The following is a description of a gene set: from publication Collison LW, Chaturvedi V, Henderson AL, Giacomin PR, Guy C, Bankoti J, Finkelstein D, Forbes K, Workman CJ, Brown SA, Rehg JE, Jones ML, Ni HT, Artis D, Turk MJ, Vignali DA (PMID 20953201) Regulatory T cells (Tregs) play a critical role in the maintenance of immunological self-tolerance. Naïve human or murine T cell treatment with the inhibitory cytokine IL35 induces a regulatory population, termed iTR35, that mediates suppression via IL35, but not IL10 or TGFβ, neither express nor require Foxp3, are strongly suppressive in five in vivo models, and exhibit in vivo stability. Treg-mediated suppression induces iTR35 generation in an IL35- and IL10-dependent manner in vitro, and in inflammatory conditions in vivo in Trichuris-infected intestines and within the tumor microenvironment, where they appear to contribute to the regulatory milieu. iTR35 may constitute a key mediator of infectious tolerance and may contribute to Treg-mediated tumor progression, and ex vivo-generated iTR35 may possess therapeutic utility. species: Homo sapiens Genes up-regulated in T conv cells: control versus treated with IL35. Human Gene Set: GSE24210_CTRL_VS_IL35_TREATED_TCONV_CD4_TCELL_UP, and this is the list of marker genes: IGKC, KLHL24, POLI, TLE5, ZMYND8, ARHGAP26, VIM, KCTD12, PIK3R4, BRAF, NUAK2, SLC26A11, KIDINS220, ITM2B, MS4A1, CREBL2, TEC, FBXL4, SGPP1, PDE2A (phosphodiesterase 2A), IL9R, RAPGEF5, ARMC3, ITGA6, VPS41, ACVR1B, RSRC1, HEPACAM2, BBS2, CDC42EP3, CRIP1, PXK, TRIM11, CRIM1, ELL3, ROCK1, KLF3, CCNL2 (NCBI Gene Id 9613), TBC1D10C, TECPR1, CRLF3, RNF139, PAK1, FANCA, CR2, MORC3, MCTP2, ARHGDIB, MCL1, RAB3IP, WDR44, RERE, EMID1, LCOR, RASGRP1, CCDC82, CD1D, TMEM123 (transmembrane protein 123), PSMB9, PTEN, GPD1L, APOBEC1, PKIB, SNX29, CREB3L2, AMER1, EEIG1, LPP, IRF2, PADI2, KDM3A (lysine demethylase 3A), H2AC25, PTPRC, SLC44A2, LTA, SNX2, PRIMPOL, PRKACB, DTX3L, CMTR1, PPP1R21, TRIOBP (NCBI Gene Id 23712), MZB1 (marginal zone B and B1 cell specific protein), BBX, GABPB2, NOD1, AFG1L, LY86, STRADB, RAC2, NCK2, JAK3, GMFG, TXNIP, CLIC1, ALDH3A2, ACKR2, NUFIP2, CLK1, CEP192, ITPR3, RASSF4, ALPK2, CAMKMT, MTSS1, MED13L, PHC3, HERC2, NOTCH2, CBFA2T3, POLG2, SFT2D2, BTG1, PRR13, SFN, CELF2, SEC11C, CDC42SE2, CNOT6L, CD40, C19orf12, PHF21A, CEP350, DFFA, CD47, JAK1, SLC50A1, NAB1 (NCBI Gene Id 4664), SHISA5, CD74, INVS (NCBI Gene Id 8014), ERMARD, C16orf54, TRAF5, PHF20L1, RCSD1 (NCBI Gene Id 92241), ING1, TAPBP, LIMK2, BCL7A, DUSP6, TMT1A, ARAP1, IFT140, UROS, EHD3, PDE1B (phosphodiesterase 1B), TRIB2, LY6D, RDM1, SF3B1, AP2A2, PLEKHO1, DUSP11, RAPGEF4, CKLF, REV3L, NCKAP1L (NCK associated protein 1 like), BLNK, CMTM7, SLAMF1, GCOM1, FRY, TLR4, PSD3, PLGRKT, HSH2D, MYL4, CEP68, TOP2B, AP4B1, HIVEP2, CYTH1, CAMK1D, PSD4, ABCB1, FGD2, CXCR5, SPATA13, USP6NL, SLC40A1, ZNF622, OXR1, TLR1, MINDY2, MTARC2, IRF2BPL, RAB19, CDKN1B, MAP3K3, TRAF3, CDC25B, DENND1C, TPST1, ZNF592, SLC35B3, SPG11, SYS1, KIZ, ITPR1